The following is a description of a gene set: Human Gene Set: MIR6840_3P species: Homo sapiens from publication Chen Y, Wang X (PMID 31504780) Genes predicted to be targets of miRBase v22 microRNA hsa-miR-6840-3p in miRDB v6.0 with MirTarget v4 prediction scores > 80 (high confidence targets)., and this is the list of marker genes: KANK4, MAU2, RCC1, DCAF8, KSR2, WSCD1, PAN2, ALPK3, RIT1, KIF13A, ZNF740, PFKFB3, DNAJC11, VAMP1, TTPAL, ZNF543, S1PR5, SLC8A2, SLC2A12, ATG4B, VPS53, NAT8L, RAB9A, CNBP, RIMS4, DUS4L, CHRM1, PLEKHA5, NT5DC3, DIAPH1, HP1BP3, TRUB1, SLIT3, FBXL18, CA10, ASIC4, ERICH1, SRF, PLB1, SERTAD1, CYLD, GALNT15, MEF2D, MDM1, DNAAF11, ADCYAP1R1, CHAC1, SPRING1, WFDC13, TRPV6, TFF3, CHN1, CMTM1, PPP1R11, EPHB2, CALCR, NETO2, JADE2, ABCD3, FBXO32, SNX22, UBR2, RELCH, HEY1, ATP8B2, TNFRSF1B, LDLRAP1 (NCBI Gene Id 81862), ADA2, VCP, FUT6, PSENEN, PHF20, NAV1, RTKN2, CNNM4, DLG4, SHISA7, FREM2, STC1, GABBR2 (gamma-aminobutyric acid type B receptor subunit 2), DLK1, CRTC1 (CREB regulated transcription coactivator 1), JAM2, KIAA0232, HLA-DMB, AIF1L, RCE1, STK38, TMEM87A, WNT4, NDST1, NR1H3, TGIF2, DHX33, PDGFA, MANBAL, GPATCH2L, CKLF-CMTM1, MALL, ZNF783, B4GALT1, STIM1, STOX2, TRARG1, HRH3, ATP6V0B, RINL, SAMD8, PDLIM2, ADCY6, TRIM66, CASP8AP2, PAX5, SLC5A5, C6orf120, TOX3, E2F2 (E2F transcription factor 2), NGDN, RNF220, SH3TC2, PDE6A, LHFPL2, PPP2R5B, SLC47A1, ZBTB6, RAPGEF4, CEP170B, TFE3, CDH9, DISC1, RALA, SRRM4, SLC6A6, ACSL1, GPX5, STK3, PANK2, MAFF, REV1, ZFYVE27, MLEC, CHTF8, PPP1R10, HMGCS2, TAP2, INTS14, HECW1, BCL2L10 (BCL2 like 10), CPXM2, BRMS1, SCN3B, TSPAN11, ZDHHC5, PDE4A, KRTCAP3, PGPEP1, RCAN2, UBTD2, TFCP2L1, MOCS1 (NCBI Gene Id 7931), MYRF, HDAC7, ANKLE2